Given this list of marker genes AMPD1, SFMBT2, SH3BP5, USP28, TTC3, SETX, SSBP2, NOMO1, DSE, ID3, C1QBP, IFT80, RPL8, IL27RA, ABCD3, GOLM2, CD2AP, ABRAXAS1, PA2G4, GRIA3, RWDD3, GGT5 (NCBI Gene Id 2687), DOCK11 (NCBI Gene Id 139818), SNHG1 (NCBI Gene Id 23642), SLC6A19, TMEM25, SESN1, CLDN5, QSER1 (glutamine and serine rich 1), SLC12A7, LRRC23, CHST15, RPL22, RAPGEF4, ELMO3, RPS10, PRDX3, CLIP1, PIKFYVE, TRAT1, RPL10A, BICDL1, SEMA4B, SLC17A9, SLC11A2, ELP3, COX10, GLT8D2, KBTBD11, RGS10, SREBF1, MIX23, CLYBL, CPNE4, SI, SESN3, SELL, LTV1, OVGP1, CCR9, TFPI, STX1A, FNTB, PATJ, DAPL1, NLE1, ADGRG5, WDR75, ZNRF1, CHD3, NEDD4L, TCF7, TAGAP, ARFGAP1, STAMBPL1, SATB1, CD320, TNFSF8, TREML2, EVL (NCBI Gene Id 51466), NSG2, RBM33 (RNA binding motif protein 33), CCR7, RAPGEF6, ITGAE, DZIP1, HSD17B1, RRAS2 (NCBI Gene Id 22800), IL6ST (NCBI Gene Id 3572), PTK2, TOP2B, EML5, CEP97, CARNS1, BRWD1, INPP4B, STOML2, TTC14, MIR448, SELENOP, SLC43A2, TANC1, RAB3IP, GALNT10, PKP1, ART4, FOXP1, KDM5B, AFP, GPATCH4, NOP58, CRLF3, FAM78A, ARHGAP15, TIMM9, ARV1, EIF3E, RPS3, CHCHD7, SPACA1, PEX5, METTL9, USP24 (NCBI Gene Id 388634), DKC1, MYC, RFLNB, RPL13, LRRC15, CRIPTO, TPCN1, SIDT1, ARID1A, PRMT3, SH3PXD2A, CELSR3, ABCA3, RCCD1, RPL36A, TDRKH, PDK1, IL7R, TLR1, LEF1, BDH1, BBC3, NRROS, ESF1 (ESF1 nucleolar pre-rRNA processing protein homolog), PLEKHA1, TET1, RPS26, IRS2, FHIT, ADCY6, WDR13, AGPAT5, TGFBR3, TMIE, PMEPA1, ENTPD2, PWP2, METTL8, PRSS12, N4BP2, SCML4, PRP4K, PPRC1, EEF1B2, XKRX, RIMOC1, KRBA1, PALS1, MAGI3, here is a description of the gene set: studied in species Homo sapiens Human Gene Set: GSE14415_INDUCED_TREG_VS_FOXP3_KO_INDUCED_TREG_UP from publication Haribhai D, Lin W, Edwards B, Ziegelbauer J, Salzman NH, Carlson MR, Li SH, Simpson PM, Chatila TA, Williams CB (PMID 19265124) Genes up-regulated in induced T reg: wildtype versus non-functional FOXP3. The gene expression profile of peripheral Foxp3+ natural regulatory T cells isolated from Foxp3/EGFP bicistronic mice was compared to that of in vitro-induced regulatory T cells and to CD4+ conventional (Foxp3-) T cells. The role of the regulatory T cell transcription factor Foxp3 in shaping the transcriptosomes of natural and induced regulatory T cells was analyzed using mice expressing a mutant FOXP3-EGFP fusion protein (Foxp3deltaEGFP). We used gene expression microarrays to examine the transcriptional programs of natural and induced regulatory T cells and the function of Foxp3 in organizing the transcriptosomes of the respective cell type